The following is a description of a gene set: Mouse Gene Set: MIR_1948_5P species: Mus musculus Genes predicted to be targets of miRBase v22 microRNA mmu_miR_1948_5p in miRDB v6.0 with MirTarget v4 prediction scores > 80 (high confidence targets). from publication Chen Y, Wang X (PMID 31504780), and this is the list of marker genes: Stk26, Sh3gl3, Zfp738, Slco6d1, Adamts20, Cyb5d2, Lmo7, Med7, Tyw3, Dnm3, Polq, Lemd3 (NCBI Gene Id 380664), Txlnb, Krit1, Tmem236, Fam78b, Ndp, Ifih1, Gpr158, Cbln2, Cyp2j12, Eomes, Nek7, Izumo3, Zic3, Bmp5, Spin4, Trp63, Rrm1, Cyp39a1, Sdr9c7, Slco1a1, Zrsr2, Nin, Aste1, Cep350, Zfp729a, Otor, 4930486L24Rik, Nbr1, Cdhr3, Sema3d, Fhod3, Nadsyn1, Gatad1, Nus1, Rsph4a, Erap1